The following is a description of a gene set: studied in species Homo sapiens Sleep regulation Human Gene Set: WP_SLEEP_REGULATION, and this is the list of marker genes: SLC29A1, ADORA2A (adenosine A2a receptor), NPS, DRD3, STAR, HTR2A, NPY2R, ADA, ADORA1, OXTR, IL6, AHCY, GHRL, PTGDS, BTBD9, GRIN2A, CST3, NLGN1, IL18, MRGPRX2, HCRTR2, UTS2, DRD2, PTGDR, CHRNB2, DRD1, DLAT, FOS, GHRH, HCRTR1, NPAS2, OXT, MTNR1B, CRH (corticotropin releasing hormone), TH, PER3, CACNA1I, UTS2R